Given this list of marker genes TRAPPC14, YRDC (yrdC N6-threonylcarbamoyltransferase domain containing), BCR, H2AX, RHOC, SLC39A5, MAP4, NCKIPSD, KLHL15, GNB5, USP46, KIF3B, FYCO1, ANLN, TMEM109, FBXW7, LAPTM4A, CCDC68, CDC25A, PEX12, NUP35, CACUL1, UXS1, ASNSD1, TVP23B, KIF23, CASP7, EFCAB14, ANKFY1, DDHD2, ZCCHC2, LYPLA2 (NCBI Gene Id 11313), MYBL1, INTS5, ZNFX1, ENTREP3, AREL1, CFAP45, HIF1AN, POLR3G (RNA polymerase III subunit G), EIF2S1, CARD10, SRPRA, SLC35A4, PPT2, UBAC1, TSR1, RFK, RAB11FIP2, SLC39A7, EGR1, JADE1 (jade family PHD finger 1), KLHL26, CCNE1, SUSD6 (sushi domain containing 6), NACC2, RAB11FIP5, JUNB, ELL, RPS6KA3, NAPEPLD (N-acyl phosphatidylethanolamine phospholipase D), LMO7, SFXN5, TRUB1, RAB22A, SDHAF2, COX10, BTRC, CDS2, AKTIP, MKRN1, MED28, TMEM245, UHMK1, CHD9, ELK3, SFR1, ZFP91 (ZFP91 zinc finger protein, atypical E3 ubiquitin ligase), ATXN7L3, UBE2R2, KIF1C, EPHA4, EXT2, ANKS1A, AP5S1, MGLL (NCBI Gene Id 152009), KIF21A, MICB, COMMD6 (COMM domain containing 6), SLC25A22, M6PR, PAF1, USP15, RNF128, CDK6, ANAPC13, TMEM9B, TGIF2, PABIR1, VPS33B, PIP4P1, SLC15A4, TPRG1L, RCE1, SAMTOR, TBCEL, GNPDA2, OSCP1, CDC37L1, EREG, PPP1R11 (NCBI Gene Id 9160), MIEF1, NCEH1, DCP2, CDC42SE2, NOB1, BCL2L12, DAZAP2, E2F7, E2F1, WWP1, GFPT1, DNAJB6, ARHGDIA, THUMPD1, PHF19, CLASP1, KBTBD4, CDC27, WEE1, PHLPP2, DEDD, IFRD2, ZFYVE9, RGMA, SPAG7 (NCBI Gene Id 9552), MAP3K2, NKIRAS1, LIMK1, C9orf40, PLEKHA3, DHDDS, HSPA1B, TMEM268, RNF138, SMURF2, CDCA4, TLK1, PON2, SPRYD3, UBTD1, SLC11A2, PCMT1, PACS1, NUBP1, PURA, BTG3 (NCBI Gene Id 10950), UBE2V1, MAPRE3, PLEKHM1, PUDP, SERPINE1, ATL3, NMD3, MACF1 (microtubule actin crosslinking factor 1), PIP4K2A, UBE2Q1, MAPK1, ATG16L1, RAB3B, IPPK, RNH1 (ribonuclease/angiogenin inhibitor 1), MRPL43, ATG9A, FOXK1, TNFRSF10B, MKNK2, DNAJC5 (DnaJ heat shock protein family (Hsp40) member C5), CBX6, F3, DYNC1LI2, TUSC2, GOLGA1, MFN2, SIRPA (signal regulatory protein alpha), TARBP2, ABI2, SLC9A1, SETD3, BIK (BCL2 interacting killer), CYB561A3, CRY2, SLC30A1, TNFSF12, ITPRIPL2, AGO1, ST6GALNAC6, FASTK, TACC1, TIAM1, SLC16A9 (solute carrier family 16 member 9), TFAP4, NLRX1, LCOR, CHEK1, CLIP4, here is a description of the gene set: Transcripts down-regulated by overexpression of MIR16 family of microRNA molecules in DLD-1 and HCT116 (colon cancer) cells hypomorphic for DICER1. species: Homo sapiens from publication Linsley PS, Schelter J, Burchard J, Kibukawa M, Martin MM, Bartz SR, Johnson JM, Cummins JM, Raymond CK, Dai H, Chau N, Cleary M, Jackson AL, Carleton M, Lim L (PMID 17242205) Human Gene Set: LINSLEY_MIR16_TARGETS microRNAs (miRNAs) are abundant, approximately 21-nucleotide, noncoding regulatory RNAs. Each miRNA may regulate hundreds of mRNA targets, but the identities of these targets and the processes they regulate are poorly understood. Here we have explored the use of microarray profiling and functional screening to identify targets and biological processes triggered by the transfection of human cells with miRNAs. We demonstrate that a family of miRNAs sharing sequence identity with miRNA-16 (miR-16) negatively regulates cellular growth and cell cycle progression. miR-16-down-regulated transcripts were enriched with genes whose silencing by small interfering RNAs causes an accumulation of cells in G(0)/G(1). Simultaneous silencing of these genes was more effective at blocking cell cycle progression than disruption of the individual genes. Thus, miR-16 coordinately regulates targets that may act in concert to control cell cycle progression.